Given this list of marker genes Ttr, Tnfaip8, Naglu, Impact, Wdr44, Tmsb4x, Castor1 (cytosolic arginine sensor for mTORC1 subunit 1), C1ra, Spi1, Upf3a, Sufu, Gopc, Casq2, Smad6, Ddx56, Ywhae, Lrrc15, Cd69, Mt3, Ywhaz (NCBI Gene Id 68643), Nfkb1, Nosip, Insig2, Usp38, Mdfi, Trim15, Laptm5, Sri, C1rb, Nucb2, Tarbp2, Pfn1, S100a7a, Prdx4, Kifbp, Myt1l, Sec14l1, Erfe, Prm2, Tssc4, Epn1, Ctnnd1, Tmsb15l, Slc39a4, Ywhab, Trem1, Flna (NCBI Gene Id 245705), Nck1, Dzip1, Usp9x, Zar1, Ywhag, Tacc3, Stat3, Nfkbia, Lcn2, Sfn, Tmsb15b2, Sdcbp, Sqstm1, Calr (NCBI Gene Id 12317), Insig1, Fth1, Hspbp1, Tmc8, Sesn2, Cdkn1a (NCBI Gene Id 12575), Nrg1, Smo, Xaf1, here is a description of the gene set: species: Mus musculus Mouse Gene Set: GOMF_MOLECULAR_SEQUESTERING_ACTIVITY Binding to a specific molecule to prevent it from interacting with other partners or to inhibit its localization to the area of the cell or complex where it is active.